Given this list of marker genes RHEB (Ras homolog, mTORC1 binding), PTPRD, GRM5, LRRTM3, HES1, MIR222, NLGN3, IL34, HIF1A, HDAC2, TIAM2 (TIAM Rac1 associated GEF 2), LRRC4B, RUFY3, BCL11A, SERPINF1, SOX8, SOX10, AMIGO3, FN1, MAN2A1, DBN1, IL6ST, AGRN, DICER1, NLGN2, VSTM5, DISC1, TRPV2, NUMB (NUMB endocytic adaptor protein), NLGN1, SRRT, IST1, BRAF, PLXND1, CLSTN1, ID4, NAP1L1, PRMT5, ANAPC2, LIG4 (DNA ligase 4), LRRTM2, CXCR4, KDM1A, IL1RAPL1, NKX6-1, SLITRK6, BDNF, RAB21, NKX2-2, SRPX2, XRCC2, GFAP, TNFRSF1B, ASPM, ARMCX5-GPRASP2, LINGO4, MECP2, MDK, NTN1, LINGO2, TSPO, PLXNB3, ANKRD27, TP73, LYN, TNFRSF12A, SPINT1, ELL3, DLG5, SMO, RND2, FMR1, SLC7A5, SHANK3, GRID2, IL1RAP, LPAR3, PRKCA, PAK1, FLRT3, MEGF8, EFNA5, RNF112, CLSTN2, SLITRK1, TTBK1, CLCN2, SLITRK2, FZD4, NR2E1, ROBO1, EPHB3, TRIM32, METRN, MAP6, SLITRK4, GHRL, DSCAM, POU4F2, DMRTA2, LRTM2, GSX2, ZNF365, SMARCD3, NIN, RELN, PLAG1, TWF2, ADCY10, PRKCI, CLSTN3, LIF, MAP3K13, ADNP, SOX11, MYB, LRRTM1, SLC30A1, NKX6-2, CDKL3, PAFAH1B1, LRP8, PLXNB1, NRP1, TBC1D24, WNT7A, RGS14 (regulator of G protein signaling 14), SKIL, CAPRIN2, CBLN1, WNT3A, ATXN1, MAP2K2, STK25, CRABP2, FGF2, STK11, PPP1CC, NRDC, ASCL1, OTP, CAMK2B, ZNF488, SEMA7A, SERPINE2, CUX2, RASSF10, MIR221, BAIAP2, TRAK1, NUMBL, NOTCH1, IFNG, FBXW8, WNT3, LRRN1, DHX36, FXR2, SHTN1 (NCBI Gene Id 57698), CAPRIN1 (NCBI Gene Id 4076), NTRK3, RELA, EPHB2, CUX1, ETV5, E2F1, ADGRB3, TPBG, ROBO2, MME, TNF, SLITRK3, TRPC5, MAPT, ZNF335, MYRF, GLI3, BMP2, MIR142, MAG, PTN, EPHB1 (EPH receptor B1, NCBI Gene Id 2047), BMPR2, UFL1, HDAC1, LTA, FXR1, HDAC6, ID2, QKI, CLCF1, IQSEC2, MAP1B, TIAM1, STAU2, NGF, EGR2, SHOX2, PRKCH, SHH, ZEB2, OXT, GDI1, CDH4, NRXN1, CX3CR1, DRD2, MTOR, SEMA4A, LIMK1, TGM2, GPER1, PAX6, ITGB1, ZFYVE27, EPHA4, HAP1, KHDC3L, L1CAM, ST8SIA2, FZD3, XRCC5, ASIC2, SEMA5A, AMIGO1, FLRT2, PLXNC1 (plexin C1), THBS2, GPRASP3, SEMA4D, MAP2K1, KIT, SMURF1, FLRT1, CTNNB1, PLXNB2, IL6, SLIT2, WDR62, LRRC24, CDKL5, AMIGO2, SRF, LRRN3 (NCBI Gene Id 92468), VEGFA, GOLGA4, FOXG1, LRP2, DCT, NEFL (NCBI Gene Id 4747), TGFB1, MACF1, DAG1, WNT2, SNW1 (SNW domain containing 1), PTPRZ1, SPEN, EEF2K, ITPKA, TENM4 (teneurin transmembrane protein 4), ADGRB2, CUL7, OLIG2, CX3CL1, NTRK1, CBLN2, CXCL12, VEGFC, NTRK2, BIN1, ADGRB1, NEURL1, ISLR2, KRAS, IL1B, OBSL1, PARP6, OPRM1, CHODL, SS18L1, MIR125B1, NPTN, CDON, SLITRK5, SYNDIG1, here is a description of the gene set: Any process that activates, maintains or increases the frequency, rate or extent of nervous system development, the origin and formation of nervous tissue. studied in species Homo sapiens Human Gene Set: GOBP_POSITIVE_REGULATION_OF_NERVOUS_SYSTEM_DEVELOPMENT